The following is a description of a gene set: The evagination of the Golgi membrane, resulting in formation of a vesicle. Mouse Gene Set: GOBP_GOLGI_VESICLE_BUDDING studied in species Mus musculus, and this is the list of marker genes: Arfgap2, Arfgap3, Myo18a, Prkci, Gbf1, Golph3l, Tmed9, Golph3